The following is a description of a gene set: species: Homo sapiens Occular cell types curated from Gautam and Hamashima et al. Multi-species single-cell transcriptomic analysis of ocular compartment regulons from publication Gautam P, Hamashima K, Chen Y, Zeng Y, Makovoz B, Parikh BH, Lee HY, Lau KA, Su X, Wong RCB, Chan WK, Li H, Blenkinsop TA, Loh YH (PMID 34584087) Human Gene Set: GAUTAM_EYE_IRIS_CILIARY_BODY_RIBOSOMAL_GENES_HIGH_FIBROBLASTS, and this is the list of marker genes: SELENOF, ACYP1, GAPDH, CMTM8, CETN2 (NCBI Gene Id 812), ETNPPL, SERF2, WIF1, DRAM2, SELENOP, SNRPD1, PFDN4, TNNC1, DIO2